Given this list of marker genes LTV1, RPS15, RAN, NOP9, RIOK2, NUP88, NPM1, XPO1, here is a description of the gene set: studied in species Homo sapiens The directed movement of a ribosomal small subunit from the nucleus into the cytoplasm. Human Gene Set: GOBP_RIBOSOMAL_SMALL_SUBUNIT_EXPORT_FROM_NUCLEUS